Given this list of marker genes CHKA, CDS1, PCYT1B, CHPT1, CHKB, CEPT1, PCYT1A, here is a description of the gene set: studied in species Homo sapiens Human Gene Set: GOBP_CDP_CHOLINE_PATHWAY The phosphatidylcholine biosynthetic process that begins with the phosphorylation of choline and ends with the combination of CDP-choline with diacylglycerol to form phosphatidylcholine.